The following is a description of a gene set: Mouse Gene Set: MP_INCREASED_INTESTINAL_ADENOMA_INCIDENCE from publication Motenko H, Neuhauser SB, O'Keefe M, Richardson JE (PMID 26092688) Mouse genes annotated to increased intestinal adenoma incidence (MP:0002404) retrieved from the Mouse Genome Informatics database via MouseMine species: Mus musculus, and this is the list of marker genes: Msh6, Msh2, Stk11, Braf, Trp53, Tpx2, Men1, Apc, Ctnnb1, Pax6, Helq, Nuak2, Lin28b, Pold1, Tnk1, Mlh1, Tmigd1, Tcf7, Pole, Cdx2, B3gnt6, Smad4